Given this list of marker genes ADORA1, GHRHR, NPY2R, MTNR1B, GHRL, KCNA2, PARP1, BTBD9, here is a description of the gene set: species: Homo sapiens Human Gene Set: GOBP_CIRCADIAN_SLEEP_WAKE_CYCLE_NON_REM_SLEEP All sleep stages in the circadian sleep/wake cycle other than REM sleep. These stages are characterized by a slowing of brain waves and other physiological functions.